Given this list of marker genes RPS14, PRKAR1A, IRF2BP2, FIP1L1, CLCN7, TET2, SF3B1, CARD9, NUMA1, PLEKHM1, AQP5, STAT5B, NABP1, NPM1, TCIRG1, HBB, PML, BCOR, RARA, STAT3, ZBTB16, MAGT1, TBL1XR1, BCHE, here is a description of the gene set: Human Gene Set: HP_CHRONIC_INFECTION Chronic infection studied in species Homo sapiens Presence of a protracted or persistent infection by a pathogen potentially related to an underlying abnormality of the immune system that is not able to clear the infection.